The following is a description of a gene set: Any of several heterotetrameric complexes that link clathrin (or another coat-forming molecule, as hypothesized for AP-3 and AP-4) to a membrane surface; they are found on coated pits and coated vesicles, and mediate sorting of cargo proteins into vesicles. Each AP complex contains two large (a beta and one of either an alpha, gamma, delta, or epsilon) subunits (110-130 kDa), a medium (mu) subunit (approximately 50 kDa), and a small (sigma) subunit (15-20 kDa). studied in species Mus musculus Mouse Gene Set: GOCC_AP_TYPE_MEMBRANE_COAT_ADAPTOR_COMPLEX, and this is the list of marker genes: Ap2m1, Aftph, Ap3s1, Tbc1d5, Ap3m1, Ap1s1, Ap3b2, Ap4m1, Ap2a1, Eps15 (NCBI Gene Id 73669), Tepsin, Ap3d1, Ap2s1, Ap5z1, Slc18a3, Sgip1, Ap2a2, Ap5s1, Ap1m2, Vps16, Ap3b1, Ston1, Vps39 (VPS39 HOPS complex subunit), Ap1m1, Vps11, Ap1s2, Ap4b1, Lrrn3, Ap5b1, Ap1g1, Ap3s2, Snap91, Vps33a (VPS33A CORVET/HOPS core subunit), Ap1b1, Ap5m1, Btbd8, Ap1s3, Ap2b1, Ap1g2, Clba1, Vps41, Ap4s1, Ap3m2, Vps18, Ston2 (stonin 2), Ap4e1